Given this list of marker genes SLC39A14, ABHD12, JUP, SLC25A4, COL6A3, PPP2R5D, PRG4, ESCO2, FHL1 (NCBI Gene Id 2273), COL7A1, DDHD2, POMT1, MYL2, SLC29A3, FLNA, DMD, MYL11, SLC12A6 (solute carrier family 12 member 6), HSPG2, LMX1B, EIF5A, SYNE1, BICD2, PI4KA, NOD2, ERGIC1, SPTBN4, COL6A1, SVIL, DAG1, PLAAT3, OPA1, C18orf32, ORAI1, MYBPC1, COG8, NSD1, LARGE1, KLHL9, MT-TE, DYRK1A (NCBI Gene Id 1859), DSP, KCNK9, CHRNG, PYROXD1, COL25A1, KY (kyphoscoliosis peptidase), C19orf12 (chromosome 19 open reading frame 12), CRPPA, BCAS3, GJB1, LMNA, HACD1, COL6A2, DPM1, ANO5, FBN2, FKBP10, TBC1D2B, HLA-DRB1, CTDP1, SYT2, IPO8, MTMR14, ALAD, NEB, MMP2, JAG2, SLC4A10, AMER1, COL12A1, ABCC9, SCARF2, MARS1, SCN4A, SPG11, CCR6, ERCC6, CAV1, PTRH2, SPTAN1, NGLY1, MMP1, ERCC8, UFC1 (ubiquitin-fold modifier conjugating enzyme 1), FKTN, GLI3, FIG4, RPL10, PHF6, SELENON, TOR1AIP1, SGCG, ADSS1, IRF5, ERCC1, ZC4H2, HNRNPA2B1, PIEZO2, TTN, APC2, PSMB8, VARS1, TNNT1, FKRP, ITGA7, CCN2, CAPN3, ATP5F1D, TGFB3, UBA1, ADAMTS15, RYR1, SCYL2, ALS2, GNS, SGCA, ERLIN2, EMD, MYOT, FGFR3, NSUN2, NT5C2, FBN1, BCOR, KIAA0319L (NCBI Gene Id 79932), NFATC2, PNPT1, LGI4, MEGF10, RTTN, TPM3, LIFR, DNM2 (NCBI Gene Id 338330), PSAT1, PIGN, TPM2, BRF1, MYH3, ADAT3, HINT1, DDR2, ERCC4, SYNE2, TMEM43, HRAS, REEP1, SLC1A4, MAP3K20, PLEC, ACTA1, here is a description of the gene set: Human Gene Set: HP_FOOT_JOINT_CONTRACTURE Foot joint contracture studied in species Homo sapiens Contractures of one or more joints of the feet meaning chronic loss of joint motion due to structural changes in non-bony tissue.